Given this list of marker genes ALDH3A2, ACAT1, IDH2, SHMT1 (serine hydroxymethyltransferase 1), ALDH1A1, MDH2, ALDH1B1, ECHS1, FH, ALDH9A1 (NCBI Gene Id 223), ACO2, ACSM5, HADH, DBT, EHHADH, ALDH2, BBOX1 (NCBI Gene Id 8424), MDH1, ACO1, here is a description of the gene set: Human Gene Set: MODULE_305 studied in species Homo sapiens CoA and fatty acid metabolism.